The following is a description of a gene set: studied in species Homo sapiens Genes up-regulated in MDA-MB-231 cells (breast cancer) after knockdown of SATB1 by RNAi. Human Gene Set: HAN_SATB1_TARGETS_UP Mechanisms underlying global changes in gene expression during tumour progression are poorly understood. SATB1 is a genome organizer that tethers multiple genomic loci and recruits chromatin-remodelling enzymes to regulate chromatin structure and gene expression. Here we show that SATB1 is expressed by aggressive breast cancer cells and its expression level has high prognostic significance (P < 0.0001), independent of lymph-node status. RNA-interference-mediated knockdown of SATB1 in highly aggressive (MDA-MB-231) cancer cells altered the expression of >genes, reversing tumorigenesis by restoring breast-like acinar polarity and inhibiting tumour growth and metastasis in vivo. Conversely, ectopic SATB1 expression in non-aggressive (SKBR3) cells led to gene expression patterns consistent with aggressive-tumour phenotypes, acquiring metastatic activity in vivo. SATB1 delineates specific epigenetic modifications at target gene loci, directly upregulating metastasis-associated genes while downregulating tumour-suppressor genes. SATB1 reprogrammes chromatin organization and the transcription profiles of breast tumours to promote growth and metastasis; this is a new mechanism of tumour progression. from publication Han HJ, Russo J, Kohwi Y, Kohwi-Shigematsu T (PMID 18337816), and this is the list of marker genes: QKI, SEC14L2, ACO2, SLC33A1, RBKS, BDNF (NCBI Gene Id 627), ZAP70, ANKRD1, SLC1A1 (NCBI Gene Id 6505), FICD, CYP51A1P2, NPC1, JAK3, GSTM3 (glutathione S-transferase mu 3), CDH16 (cadherin 16), M6PR, S100P, ZNF430, IFNAR1 (NCBI Gene Id 3454), BCHE, GGT1, GPNMB, FSTL1, PRSS2, FKBP1A, RAB11FIP1, PLXNB2, NOL3, PELI2, RARG, ATG7, SPTBN1, TFF1, DENND4A, N4BP2L2, WNT5A, RABL2B, SHANK2, CELSR1, EFEMP1, SAP30L, TSPO, NCOA3, ATP13A2, PPME1, REEP3, ZNF804A, RBCK1, GNAI1, CDH4, KAT6B, MMP1, B3GALNT1 (beta-1,3-N-acetylgalactosaminyltransferase 1 (Globoside blood group)), PSMB7, GOLGA2, LDOC1, FAM149B1, OSMR, LZTFL1, NELL2, ACAT2, SYNGR3, EPB41L3, IGF2R, PCDH9, BCAP29, MFN1, BMP3, TUBA4A, EDRF1, APOL3, DENND1A, LPAR1, MCMBP, MX1, TSC1, RABAC1, IL1B, CYP26B1, MITF, CSF2RA, UCP2, SLC16A1, TPCN2, TCEA2, FHL1, ALDOC, OAS1, PAEP, SAMM50, NME1, SULT1C2, DNAJB6, YIPF6, SLPI, ALG12, SHTN1, CHRDL1, LSS, TGFBI, SBF1, ATXN10, XBP1, ENO2, CYB5R3, APOL2, ZNF600, HRH1, CDH3, CEMIP2, DNAJB12, CA12, NDUFA6, NDUFV2, CDH1, FZD4, TOR1B, ADSL, WASF3, ADARB1, NNMT, CASP1, TPM1, NUP50, RANGAP1, NR2F2 (nuclear receptor subfamily 2 group F member 2), GRK5, C4orf19, COL6A2, ST3GAL6, EIF2AK3, ATP11B, ARMC8, FYN, FBXO10, TAF1B, MAFF, SLC30A1, PDHX, GPR35, CLDN10, LAMA5, DENND5B, ARL8B, PAPSS2, AHI1, DCTN5, KLF7, NUDT13 (nudix hydrolase 13), TCF7L2, NCAPH2, CASP4, SERPINH1, GALNT1, PACSIN2, ARNT2 (NCBI Gene Id 9915), TOX, RPS6KA2, RAB8B, UTP20, CSTA, PLPP3, INSIG2, ATP13A3 (ATPase 13A3), NDRG1, P4HA1, STXBP1, RRP15, TIGAR, MLLT11, PDE4B, PLAC1, PDE4D, NAGA, CLDN1, NEO1, ADGRG6 (NCBI Gene Id 57211), LAMB2, MKNK2, MATN2, MX2, RGPD5, ST13, MBP, CD40, OGG1, GRAMD2B, SORL1, CCL2, PTK6, CXCL8, MYO1D, LIMCH1, F3, ALG13, PMP22, INSL4, EVI2B, CDS2, IFIT3, DNAJC6, SEPTIN6, RIMS2, GABRA2, IL7R, DNAJB9, BRMS1, SLC2A6, PYROXD1, TCIM, RBM19 (RNA binding motif protein 19), SFN (stratifin), ENG, RAB11FIP2, G3BP1, LGALS8, WDR83OS, RC3H2, ACAA1, DENND10, ASPH, DNAJB4, ADM, SPAG4, PLOD2, AIFM2, CALD1, PIR, TFAP2C, MICALL1, APOC1, TCF20, SLC25A17, BIK, HOXB7, TTPAL, ARFGAP3, ZNF202, TBL1X, EEF1A2, OAS3, CASP7, DIO1, EPAS1, CD24, MAT2A, FLT1, LATS1, PTPRF, OSTM1, PDXK, CTSZ, SYNGR1, SGPL1, SLC7A11, GRAP2, GGCX, LINC00342, PRKAG2, DDX10, BST2, MAGEB2, CPD, CD82, SHOC2, TMEM45B, CEMIP, SCO2, CRELD2, FADS3, CDH19, HYI, IL6, STXBP6, PXDN, ATM, HMGCS1, INHBA, PI3, DESI1, RBX1, SETX, PPP2R2D, WASHC4, SLCO1B3, QPCT, RHOB, HLA-DOA, IGFBP5, SRGN, BCAS4, TP53I3, F2RL2, CCPG1, NEDD4, SLC17A9 (NCBI Gene Id 63910), CAMSAP2, SQLE, HDAC4, CNOT10, TMEM45A, CD164, LAMB1, SHFL, ISG20, MCOLN3, NKTR, ANOS1, KLF5, ZNF35, PRMT6, ANTXR1, CTNNB1, RETREG1, RASGRF1, MAPK11, WDR77, NACC2, CDH6, CHST3, PDCD4, TNS1, KISS1, FNDC3B, BASP1, LIPA, CENATAC, VPS13C, PLAT, PPP6R2, HTR2C, VLDLR, KRT81, IL32 (interleukin 32), CXADR (CXADR Ig-like cell adhesion molecule), NEAT1, L3MBTL1, EPM2AIP1 (EPM2A interacting protein 1), SERPINB8, PDGFRL, TOB2, NEDD9, CSPG5, ZCCHC24, PDE10A, LTBP1, TOR1A, PTGS2, AK4, IL18R1, C10orf88, ECHDC1, EPB41L1, FST, MSMO1, CRY1, RRP7A, TRMT61A, PUS7, MYL9, IL11, PTPRE, CHST15, MEGF9, HMGCR, MMP10, TST, ZRANB2, PRSS1, AUP1, IL13RA2, TPCN1, RNF41, COL4A5, SDC2, BNIP3, GLRX, DHCR24, ITPR1, NINJ2, RND3, ARSA, TTC38, TXNRD2, PIK3CD, ADGRE1, TNFSF15, DUSP1, AP1M2, ULBP2, CD34, GPR21, TMSB15B, CXCL1, TGFB2 (transforming growth factor beta 2), LINC01963, PDE8A, KIAA0930, TAP1, CRYBB2, INHBE, CITED2 (Cbp/p300 interacting transactivator with Glu/Asp rich carboxy-terminal domain 2), SAMHD1, LIF, DDIT4, SH3GLB2 (NCBI Gene Id 56904), IL18, BRD1, PMM1, HYAL3, ATRN, CCNG2, TMEM132A, CERK, PHTF1, MPZL2, MCAM, TMEM158, ASL, BHLHE40, UAP1L1, RAB22A, SLC2A3 (solute carrier family 2 member 3), DDAH1, IFIT2